The following is a description of a gene set: Poor suck Human Gene Set: HP_POOR_SUCK An inadequate sucking reflex, resulting in the difficult of newborns to be breast-fed. studied in species Homo sapiens, and this is the list of marker genes: VRK1, STIL, RERE, MPV17, SLC5A7, BRAF, BMP4, ARX, AASS, MKRN3, CRIPTO, TRMU, GNB2 (G protein subunit beta 2), SMARCB1, PTPN23, DST, SIK1, GBA1, SOX11, OCA2, LAMB2, TP63, STAG2, NODAL, ZIC2, HERC2, PTCH1, ZNF699, PLCH1, CNTN1, EIF4A2, SPTBN1, RAPSN, NUDT2, COL2A1, SNRPN, IRF6, GNAO1, MEG3, NIPBL, DISP1, GCSH, MYO9A, ARV1, VAMP1, SIM1, DMXL2, TRMT10C, TRIO, DPYD, OTC, SLC25A22, TSFM, PEX2, PTS, CHRNE, ECHS1, NECTIN1 (NCBI Gene Id 84853), RARS2, CASK, SPTBN4, FGF8, GCH1, GGPS1, SLC18A3, HADHB, CHRND, RIC1, USP7, NUP214, SLC32A1, VPS13B, SLC25A19, DLX4, GLRA2, GRHL3, UQCRC2, TRIM8, ASPA, CHRNA1, RTL1 (NCBI Gene Id 651665), CHAT, LYRM4, MTM1, TSEN2, MECP2, KMT5B, ALG12, PEX12, SMARCC2, SNAP25, UBA1, TALDO1, TBC1D24, SATB2, TGIF1, DLG1, UBB, KCNA1, PEX5, ARHGAP29, ZFX, PEX19, CHRNB1, DLL1, ATP6V1B2, MT-TE, SIX3, ATPAF2, PIGQ, GAS1, TSEN54, NDUFS8, DYRK1A (dual specificity tyrosine phosphorylation regulated kinase 1A), HTRA2, PQBP1, NAA20, UBE3A, GRIN1, SEPSECS, SLC52A1, NPAP1, FGFR1, PPP1R21, SNORD116-1, SHH, PWAR1, NONO, CDKL5, DLK1, KIF5A, COL13A1, SMC1A, TSEN34, ATP7A, PIGP, MSX1 (NCBI Gene Id 4487), PWRN1, NEUROD2, PNKP, COLQ, SCN1B, COBLL1, SYT2, CDON, HRAS, CBL, ATP6V0A1, GRM7, ATRX, PDGFRA, GLI2, HADHA, ARHGEF38, SNORD115-1 (NCBI Gene Id 338433), CDH1, ARID1A, FOXH1, SLC25A1, NADK2, PLAA, AGRN, RHBDF2, DHCR7, UGP2, MAGEL2, IDH1, POGZ, SCN2A, TSEN15